Given this list of marker genes FOXP3, BRAF, BTD, ATRX, IL17RC, CYBA, ITGB4, LAMB3, DOCK8, IL17RA, LYST, GFI1, STAT3, NAE1, IL7, IKBKB, GJB2, LCP2, PRDM12, SASH3, UROS, EGFR, DCLRE1C, ZAP70, TMC8, ADAM17, TCIRG1, IKBKG, FERMT3, CARD9, STAT1, IL2RG, KRT1, IGLL1, TRAC, TCF3, XIAP, FOXP1, CLEC7A, KRT5, PKP1, DSE, OTULIN, STAT6, DOCK2, NFKBIA, RORC, NFKB1 (nuclear factor kappa B subunit 1), NR3C1, PIK3R1, GINS1, LCK, JAK3, DSG1, PSEN1, SRP19, MBTPS2, NFE2L2, CIITA, CD79B, MVK, CD3D, GJB6, SP110, BLNK, CDH23, UBE2A, SEC61A1, USP48, RFXANK, IRAK4, NCF1, EPG5, TP53, ITGA6 (NCBI Gene Id 3655), CHST14, CARMIL2, MRTFA, IL6R, RFX5, USP8, HYOU1, GJC2, KRT14, CD40LG, PIK3CD, LAMA3, COL7A1, SPINK5, SYK, FOXC2 (forkhead box C2), PSMB10, CD3E, CD79A, EPHB4, ELANE, TMC6, CYBB, NCF2, POLR3A, LAMC2, BLOC1S6, IL7R, PSENEN, TFRC, CORO1A, PIK3CG, AIRE, TRAF3IP2, IL2RA, CFI, ZNF341, MBL2, CIB1, BTK, UROD, TLR8, MYD88, CD247, ITGB2, IL6ST, GATA1, FERMT1, MAP3K14, LRRC8A, SREBF1, MMP1, STK4, ADA, AP3B1, WDR1, SPI1, IL10RA, FOXN1, IL17F, CTSC, CD3G, KNSTRN, IGHM, RFXAP, CLPB, PGM3, SLC39A7, here is a description of the gene set: Human Gene Set: HP_RECURRENT_SKIN_INFECTIONS Infections of the skin that happen multiple times. Recurrent skin infections studied in species Homo sapiens